Given this list of marker genes Itgb3, Plcg1, Src, Yes1, Ptpn11, Lck, Inpp5d, Lyn, Itgav, Ptpn6, Fyn, Pecam1, here is a description of the gene set: studied in species Mus musculus Mouse Gene Set: REACTOME_PECAM1_INTERACTIONS PECAM1 interactions